Given this list of marker genes Mir27a, Tarbp2, Dicer1, Ago3, Ago2, Prkra, Dhx9, Ago4, Ago1, Mir28a, here is a description of the gene set: A trimeric protein complex required for the formation of a mature RNA-induced silencing complex (RISC). In humans the complex is composed of the endonuclease Dicer (DICER1), TRBP (TARBP2) and the Argonaute protein Ago2 (EIF2C2/AGO2). Within the complex, Dicer and TRBP are required to process precursor miRNAs (pre-miRNAs) to mature miRNAs and then load them onto Ago2. Ago2 bound to the mature miRNA constitutes the minimal RISC and may subsequently dissociate from Dicer and TRBP. This complex has endoribonuclease activity. Mouse Gene Set: GOCC_RISC_LOADING_COMPLEX species: Mus musculus